The following is a description of a gene set: part of: Cell Cycle, Mitotic Reactome Pathway: M Phase Mitosis, or the M phase, involves nuclear division and cytokinesis, where two identical daughter cells are produced. Mitosis involves prophase, prometaphase, metaphase, anaphase, and telophase. Finally, cytokinesis leads to cell division. The phase between two M phases is called the interphase; it encompasses the G1, S, and G2 phases of the cell cycle. studied in species Homo sapiens, and this is the list of marker genes: GORASP1, TUBB2B, KIF2B, ESPL1, UBE2I, CEP135, PSMC2, RAB1A, ZWILCH, TUBA1B, WAPL, H2AC18, MAPK3, PSMA3, CDCA5, CDK5RAP2, CCP110, HAUS7, ACTR1A, CEP78, CEP41, MAPK1, ANAPC2, OFD1, CEP164, CHMP2B, CENPM, PAFAH1B1 (NCBI Gene Id 5048), HAUS8, HAUS2, TUBB4B, NDC80, TUBGCP5, AHCTF1, H2BC11, NUP98, SMC3, LPIN3, CHMP4A, CLASP1, H2BC26 (H2B clustered histone 26), RPS27A, H2BC13, BIRC5, PTTG1, CEP192, ANAPC16, ANAPC15, CENPF, PSMD14, PSMB7, KPNB1, H2AX (H2A.X variant histone), TUBGCP4 (NCBI Gene Id 27229), H4C1, CHMP4B, PSMC3, MAD1L1, NUF2, TUBB6, MZT2B, PSMD7, DYNC1LI2, LPIN2, H2AJ, PSMA4, PSMD13, XPO1, DYNC1I1, TUBB8, MZT2A, RANBP2, TUBA3D, H2AC14, CENPT, PPP2R1B, PSMA2, GOLGA2, NME7, PSMD1, HAUS3, CEP63, PSMD2, PRKAR2B, CEP72, H2AB1, NUP133, USO1, NUP85, SKA2, CSNK1D, H3C15 (H3 clustered histone 15), CENPU, TUBG1, CDC20, ANAPC11, TUBA1A, RANGAP1, SMC4, TUBAL3, CDC26, H2BC1, TUBGCP2, CDC27, GORASP2, CEP250, NEK2, NCAPD3, UBE2D1, PHF8, NUDC, PSMB4, KIF18A, PSMC1, TUBGCP6, DCTN2, NUP42, NUP155, PCNT, LPIN1, VRK2, TUBB8B, PPP1CC, KMT5A (lysine methyltransferase 5A, NCBI Gene Id 387893), PRKCB, H2BC3, ANKLE2, NCAPD2, CDK1, MAPRE1, NEK6, PSMA5, DYNC1I2, H3-4, KIF23, NUP58, KIF20A, TMPO, PPP2R5D, PSMA7 (NCBI Gene Id 5688), IST1 (NCBI Gene Id 9798), PPP2CB, NUP54, TUBA3C, PSMB3, NDE1, NUP214, TUBA4B, TUBA4A, CLIP1, NUP188, DSN1, UBE2S, FIRRM, NUP153, CEP57, SIRT2, SPC24, PSMA1, SUMO1, NUP62, PPP2R5E, CHMP3, BUB3, PCM1, NUP50, PPP2R5A, H2AC4, CENPN, CENPH, NDEL1 (nudE neurodevelopment protein 1 like 1), NEDD1, VPS4A, TPR, SPDL1, PSMC6, BUB1B, PPP2R2A, CSNK2B, LEMD2, RAE1, SPAST, ZW10 (zw10 kinetochore protein), RPS27, SMC2, NEK9, NCAPH2, DCTN3 (dynactin subunit 3), KIF2A, CEP43, NUP37, NUMA1, ARPP19, PLK4, PLK1, ALMS1, SEC13, TUBA8, DYNLL1, POM121, EML4, SGO2, H2BC12L, NUP160, PRKACA, ITGB3BP, VRK1, YWHAE, CENPE, H2BC4, ANAPC1, ODF2, H2AC6, TUBB, CNEP1R1, STAG2, MASTL, DYNC1H1, TUBB2A, PSMD3, H2BC14, ANAPC5, BANF1, UBE2C (NCBI Gene Id 11065), TUBB4A, CCNB2, CTDNEP1, PSMC5, CENPK, B9D2, CENPL, UBA52, H2BC5, PSMB6, KNL1, DYNLL2, CDCA8, ANAPC7, CENPO, TUBB3, DYNC1LI1, NCAPH, CC2D1B, RAB1B, NUP205, H2AZ2, NCAPG2, HAUS4, KIF2C, RAB2A, CENPP, CETN2, SSNA1, MIS12, SET, SMC1A, CEP290, SPC25, RCC1, NUP210 (NCBI Gene Id 79985), AAAS, CLASP2, STAG1, HAUS5, CENPQ, MAU2, NUP93, CHMP7, TNPO1, HSP90AA1, UBE2E1, PPP2CA, LMNA, CCNB1, PPP2R5C, SDCCAG8, ZWINT, CEP131, ADRM1, AURKB, DCTN1, NSL1, AKAP9, BUB1, ENSA, LBR, HAUS6 (NCBI Gene Id 54801), H2BC21, CHMP2A, CHMP6, NINL, PRKCA, PSMD12, TAOK1, SEH1L (NCBI Gene Id 81929), CSNK2A2, PSMC4, CENPI, PSMB5, CKAP5, LEMD3, H2BC12, NDC1, CEP76, SGO1, PSMA6, RCC2, NUP88, CNTRL, POM121C, HDAC8, NEK7, UBB, INCENP, CENPC, CENPS, ANAPC10, H2BC17, PDS5A, ERCC6L, SFI1, UBC, PSMB1, RAD21, MAD2L1, PPP2R2D, CSNK1E, PMF1, NIPBL, TUBA1C, KNTC1 (kinetochore associated 1), BLZF1, PSMD8, PPP2R1A, H2BC15, SEM1, HAUS1, H3-3A (NCBI Gene Id 3020), ANAPC4, PPP2R5B, NUP43, NUP107, H2AC7 (NCBI Gene Id 3013), H2BC9, CSNK2A1, PDS5B, YWHAG, MZT1, EMD, PSMB2, CHMP4C, CPAP, NUP35, MCPH1, RAN, NCAPG, CEP70, TUBB1, TUBGCP3, H2AC20, PSMD11, CDC16 (NCBI Gene Id 8881), H3C1, SKA1, TUBA3E, PSMD6, LMNB1, CDC23, RB1, CENPA, FBXO5, CEP152, TUBG2